The following is a description of a gene set: species: Homo sapiens The process in which a mesodermal, bone marrow or neural crest cell acquires specialized features of an endothelial cell, a thin flattened cell. A layer of such cells lines the inside surfaces of body cavities, blood vessels, and lymph vessels, making up the endothelium. Human Gene Set: GOBP_ENDOTHELIAL_CELL_DIFFERENTIATION, and this is the list of marker genes: GSTM3, TNMD, JAG1, FOXJ2, MIR150, MARVELD2, AFDN, CLDN3, TJP2, S1PR1, ZDHHC21, SETSIP, STC1, MIR181A2, HEY2, CLDN1, AMOTL2, RAP2C, ARHGEF26, RAPGEF1, TNF, RAPGEF6, PDE4D, NOTCH1, MIR181B1, MESP1, SMAD4, PDE2A, TNFRSF1A, MIR1-1, FSTL1, BMPR2, NRP1 (NCBI Gene Id 8829), ICAM1, SCUBE1, VEZF1, CDH5, MIR34A, NRG1, PTPRS, MYD88, PROC, EDNRA, TMEM100, CLDN5, ID1, TJP1, COL18A1, FZD4, PDPN, KDR, ATOH8 (NCBI Gene Id 84913), BMP6, EDNRB, CLIC4 (chloride intracellular channel 4), BARX1, CTNNB1 (catenin beta 1), S1PR2, MIR199B, ROBO4, RDX, RAPGEF3, ROCK1, MSN, HOXB5, PLOD3, GDF2, F2RL1, FZD2, MYADM, PPP1R16B, VEGFA, ACVR1 (activin A receptor type 1), BTG1, PECAM1, ADD1, ETV2, FZD1, KDM6B, HPSE, ACVR2B, NDP, DLL1, RBPJ, PPP1R12A, IL1B, LIPA, MAGI1, ZEB1, TIE1, CEACAM1, EZR, PROX1, HAPLN2, MET, MIR200C, PLCB1, EDF1, FOXP3, RAPGEF2, RAB1A, VCL, TJP3, F11R, ROCK2, MIR495, NR2F2, S1PR3, DSG2, CCM2, MIR21, MIR99B, HEY1, SOX18 (SRY-box transcription factor 18), FASN, HOXA13, BMP4, NOTCH4, RAB1B, IKBKB, HEG1, RAP1B, RAP1A, MIR10A, ACVRL1, APOLD1, RAP2B, GPX1, SOX17